Given this list of marker genes CLEC7A, SCIMP, CAMK4, DHX36 (DEAH-box helicase 36), NOD2, KIT, DDX21, TICAM1, PLCG2, MAVS, RIGI, DDX1, here is a description of the gene set: species: Homo sapiens Any process that activates or increases the frequency, rate, or extent of dendritic cell cytokine production. Human Gene Set: GOBP_POSITIVE_REGULATION_OF_DENDRITIC_CELL_CYTOKINE_PRODUCTION